The following is a description of a gene set: studied in species Mus musculus Mouse Gene Set: GOBP_CARBON_CATABOLITE_REGULATION_OF_TRANSCRIPTION A transcription regulation process in which the presence of one carbon source leads to the modulation of the frequency, rate, or extent of transcription of specific genes involved in the metabolism of other carbon sources., and this is the list of marker genes: Srf, Ncoa1, Usf2 (NCBI Gene Id 22282), Mlx, Sik2, Ogt, Usf1, Kat2b, Mlxipl